Given this list of marker genes Cacna1a, Htr2c, Htr6, Slc18a3, Adora2a, Tacr2, Slc44a4, Chrna3, here is a description of the gene set: studied in species Mus musculus Mouse Gene Set: GOBP_ACETYLCHOLINE_SECRETION The regulated release of acetylcholine by a cell.